The following is a description of a gene set: Human Gene Set: GSE1460_CD4_THYMOCYTE_VS_NAIVE_CD4_TCELL_ADULT_BLOOD_DN species: Homo sapiens Genes down-regulated in comparison of CD4 thymocytes versus naive CD4 T cells from adult blood. Subpopulations of human fetal thymocyte and circulating naïve T cells were obtained through FACS sorting, including CD3-CD4+CD8- intrathymic T progenitor cells (ITTP), CD3intCD4+CD8+ \double positive\ thymocytes (DP), CD3highCD4+CD8- \single positive\ thymocytes (SP4), CD3+CD4+CD8-CD45RA+CD62L+ naive T cells from cord blood (CB4+), and CD3+CD4+CD8-CD45RA+CD62L+ naive T cells from adult blood (AB4+). from publication Lee MS, Hanspers K, Barker CS, Korn AP, McCune JM (PMID 15210650), and this is the list of marker genes: ZNF23, RPL19, DHRS9, SERPINA1, CTSF, TMC6, PPIP5K1 (diphosphoinositol pentakisphosphate kinase 1), EIF3G, RPL32, CEP68, NAP1L2, DOCK9, DHRS7, FAU, LTA4H, BMERB1, SNPH, DPH5, SMIM27, POLR1D, ZNF331, BCL2A1, DLG4, SMAGP, BTF3, RNF113A, RPL10P17 (ribosomal protein L10 pseudogene 17), KLF3, DIS3, PYGO1 (NCBI Gene Id 283658), PDE4B, NPEPL1, PASK, APOL2, ECI1, POLR2F, CPQ, CD48 (CD48 molecule), CCDC88C, S100A4, PSME1, CKAP4, FNDC3B, CREB3L2, DDX28, CSF3, MYG1, RPL27A, CUTA, HEMK1, RPS6, APOL3, CRADD, PODNL1, ZMYM6, NCK2, SCPEP1, COQ8A, MARK1, AKAP4, CD63 (NCBI Gene Id 967), KRTAP5-8, PIK3IP1, LGI2 (leucine rich repeat LGI family member 2), RAP1GAP2, MPHOSPH8, NPRL2, THG1L, ENDOD1, ACAT1, NIT2, AHNAK, HABP4, ADORA1, LY75, ATP5PD, RPL23AP7, CBY1, MAP3K5, TMEM204, SULT1B1, NOL9, NACC2, PBXIP1, IL6R, NELL2, SMIM8, RSRP1, LRIG1, ZNF204P, EPS8L2, NPC2, INPP1, TMEM140, PIM1, GABRD, PXN, CRYBG1, EOLA1, SQSTM1, MRPL40, ACP6, DDO, GCDH, ST13, SPSB3, FBXL15, ARHGEF10, CFAP46, ALCAM (activated leukocyte cell adhesion molecule), CBX6, KLK1, BORCS6, DDT, MVP, PEX16, IGF1, MRPS22, PLEKHA1, ADAM8, PKD2L1, C1RL, TSC22D3, RADX, RPS9, SORCS3, NR3C2, PDE4DIP, BTN3A3, NHERF1, ZNF394, PDXK, SVIL, RPL41, ASNSD1, BGLAP (NCBI Gene Id 632), FGF9, CIB1 (NCBI Gene Id 10519), SELPLG, NAA10, TMEM186, HLCS, C11orf21 (chromosome 11 open reading frame 21), TBC1D4, IQSEC1, KLF6, DHRS12, NOL7, GPR75, PLP2, C3orf18, ATP6V1G1, WFS1, SORL1, EIF3K, NLRP1, KCNH2, LDOC1, GIMAP4, HRH2, MLN, HOXB2, CRYL1, UPP1, MORC2, GSTK1, SEL1L3, ASNS, CDC14B, REXO2, C1orf115, VTI1B, RNF130, TBK1, REX1BD, EPPK1, DUSP1, STK10, TH, BST2, RPL10, EZH1, PRKCA, AAK1, DENND4B, MICA, LDLRAP1, NOD1, USP21, FTL, AEN, STAT4, KLF2, CXCR4, FAM117A, PPP6R2, CBR3, FUCA1, PPP3CC